Given this list of marker genes EEF1A2, KRT17, YWHAZ, FGR, MDM2, EIF5A, CCNE1, IGFBP3, NFKB1, FABP5, MMP7, HAP1, EEF1G, CALR, HP, KRT19, RHOA, DPF3, P4HB, KIF11, KRT18, GSTM4, PRDX1, MAP4, RAC1, CDC25B, GSTP1, PGK1, LGALS1, KRT8, HSPB1 (heat shock protein family B (small) member 1), ALDH1A1, TUBB, RABGGTB, CSF2, MCM3, CDC42, PSMB6, ZBTB17, HCK, S100A2, here is a description of the gene set: Proteins showing significant overexpression in lung cancer cell lines relative to normal bronchial epithelial cell lines. studied in species Homo sapiens Amplification and overexpression of putative oncogenes confer growth advantages for tumor development. We used a functional genomic approach that integrated simultaneous genomic and transcript microarray, proteomics, and tissue microarray analyses to directly identify putative oncogenes in lung adenocarcinoma. We first identified genes with increases in both genomic copy number and transcript in six lung adenocarcinoma cell lines. Next, we used two-dimensional polyacrylamide gel electrophoresis and mass spectrometry to identify 42 proteins that were overexpressed in the cancer cells relative to normal cells. Comparing the genes with the 42 proteins, we identified four genes - PRDX1, EEF1A2, CALR, and KCIP-1 - in which elevated protein expression correlated with both increased DNA copy number and increased transcript levels (all r > 0.84, two-sided P < 0.05). These findings were validated by Southern, Northern, and Western blotting. Specific inhibition of EEF1A2 and KCIP-1 expression with siRNA in the four cell lines tested suppressed proliferation and induced apoptosis. Parallel fluorescence in situ hybridization and immunohistochemical analyses of EEF1A2 and KCIP-1 in tissue microarrays from patients with lung adenocarcinoma showed that gene amplification was associated with high protein expression for both genes and that protein overexpression was related to tumor grade, disease stage, Ki-67 expression, and a shorter survival of patients. The amplification of EEF1A2 and KCIP-1 and the presence of overexpressed protein in tumor samples strongly suggest that these genes could be oncogenes and hence potential targets for diagnosis and therapy in lung adenocarcinoma. Human Gene Set: LI_LUNG_CANCER from publication Li R, Wang H, Bekele BN, Yin Z, Caraway NP, Katz RL, Stass SA, Jiang F (PMID 16369491)